The following is a description of a gene set: Functions during translation by binding to RNA during polypeptide synthesis at the ribosome. Mouse Gene Set: GOMF_TRANSLATION_FACTOR_ACTIVITY_RNA_BINDING species: Mus musculus, and this is the list of marker genes: Eif2s3x, Cpeb2, Eif2b3, Mtif3, Eif4g2, Cpeb3, Cpeb4, Eif4g1, Mtif2, Eef2k, Cpeb1